Given this list of marker genes Grhl2, Fzd5, Llgl2, Fgfr2, St14, Adm, Tmed2, Spint2, Il10, Gcm1, Socs3, Spint1, Grb2, Rspo3 (R-spondin 3), here is a description of the gene set: The process in which the branches of the fetal placental villi are generated and organized. The villous part of the placenta is called the labyrinth layer. Mouse Gene Set: GOBP_BRANCHING_INVOLVED_IN_LABYRINTHINE_LAYER_MORPHOGENESIS species: Mus musculus